Given this list of marker genes Myadm, Dlc1, Wwc1, Clip1, Spata13, Als2, Asap3, Actn1, Myh9, Ptprz1, Iqgap1, Pak1, Twf1, Ezr (ezrin), Cd2ap, Myo10, Dbnl, Kank1, Gsn (gelsolin), Bloc1s6, Hip1r, Itgb1, Tirap, Pecam1, Rasgrp2, Mtmr14, Psd, Podxl (NCBI Gene Id 27205), Tpm1, Apc, Acap2, Cyfip1, Fam107a, Cdk6, Synj2, Cspg4, Fgr, Baiap2, Nme2, Sh3bgrl3, Mefv, Macf1, S100b, Pdlim7, Itgb3, Inpp5j, Arhgap18, Pde9a, Cobl, Cyth2, Bmx, Tesc, Wasf2, Bcar1, Arap3, Trpm7, Fermt1, Adam17 (NCBI Gene Id 236174), Tln2, Notch1, Pdgfrb, Inpp5e, Mtss2, Tiam1, Kif18a, Arf4, Arhgef7, Ptprj, Ptk6, S100a6, Klhl2, Rdx, Mkln1, Itgav, Fgd5, Spry2, Myo1c, Rigi (NCBI Gene Id 230073), Epb41l5, Arhgap45, Cdc37, Arhgap1, Pla2g4f, Eps8l3 (EPS8-like 3), Myo5a, Appl1, Pdxp, Eps8, C2cd5, Aif1, Nherf1, Itga5, Egfr, Mtmr6 (NCBI Gene Id 219135), Diaph1, Arpc2, Klhl41, Sntg1, Myo9b, Sh2d3c, Itgb1bp1, Psd2, Lcp1, Rab34, Cdkl5, Cyth3, Fscn3, Eef1a1, Abl1, Tlr4, Them4, Tmem87a, Mtm1, Cib1, Pacsin1, Nckap1, Plek, Akt2, Rps3, Clasp2, Samsn1, Rock1, Pacsin2, Rab22a, Rab5a, S100a11, Psd3 (NCBI Gene Id 80295), Layn, Jcad (NCBI Gene Id 68804), Amot, Gnas, Fscn1, Src, Appl2, Arfip2, Lima1, Snx5, Anxa2, Mtmr9, Trpv4, Plcg1, Arhgef2, S100a11-ps, Abca7, Pip5k1c, Pdpn, Pip5k1a, Plekho1, Tln1, Sh2b1, Frmd4b, Snx9, Palld, Fgd2, Cttn, Map2, Capg, Vil1, Tmod3, Ppp1r9b, Rhoa, Eps8l2, Nf2, Gas7, Aif1l, Dnm2, Scimp, Cit, Rac1, Wipf1, Plekha1, Coro1c, Myo6, Inpp5k, Spry4, Cfl1, Eps8l1, Sh2b2, Fgd1, Sh3yl1, Arf6, Atp6v1b2, Rasa1 (NCBI Gene Id 218397), Epha2, Ksr1, Carmil2, Kcnn4, Psd4, Nme1, Fap, Tnfrsf12a, Actr3, Knstrn, Rinl, Erbb2, Plcg2, here is a description of the gene set: Mouse Gene Set: GOCC_RUFFLE species: Mus musculus Projection at the leading edge of a crawling cell; the protrusions are supported by a microfilament meshwork.